The following is a description of a gene set: studied in species Mus musculus Mouse Gene Set: GOCC_LAMELLIPODIUM A thin sheetlike process extended by the leading edge of a migrating cell or extending cell process; contains a dense meshwork of actin filaments., and this is the list of marker genes: Scyl3, Bcar1, Wasf3, Abi3bp, Dmd, Flot2, Dbnl, Ptprz1, Dpp4, Scrib, Fgd1, Apc, Nckap1, Dgkz, Arpc3 (NCBI Gene Id 80396), Dysf (NCBI Gene Id 26903), Ccdc88a, Pkn2, Abi3, Arhgef6, Tiam2, Phpt1, Als2, Spata13, Rac2, Plce1, Mylk, Pxn, Fermt2, Pabpc1, Casp8, Pld2, Dynlt1f, Pkd2, Dbn1, Snx2, Piezo1 (NCBI Gene Id 234839), Dpysl3, Myo10, Palld, Swap70, Ptk2b, Actg2, Coro1a, Phactr4 (phosphatase and actin regulator 4), Pdpn, Ctnna1, Cdk5, Fam89b, Caprin1, Itgav, Rac1, Tescl, Syne2, Ilk, Myo1g, Sh3bp1, Acta1 (actin alpha 1, skeletal muscle), Stx2, Arap3, Mtss2, Gm28729, Ablim3, Wasf2, Stx3, Pstpip1, Twf2, Ptpn13, Pik3ca, Plekhh2 (pleckstrin homology domain containing, family H (with MyTH4 domain) member 2), Cib1, Rac3, Gsn, Igf2bp1, Parva, Dusp22, Tsc1, Mcf2l, Trpv4, Cyfip1, Itgb1bp1, Kitl, Stx4a, Klhl2, Dynlt1b, Actc1, Myh10, Abl2, Arpin, Ctnna3, Nradd, Plekhg5, Itgb3, Arpc5, Gdpd2, Dynlt1c, Cfl1, Tmod3, Arhgap31, Fat1, Ptk2, Slc39a6, Ctnnb1, Rab13, Coro1b, Nrbp1, P4hb, Inppl1, Trpv2, Coro1c, Rab3ip, Dynlt1a, Nedd9, Brk1, Dag1, Myo9b, Ajuba, Srcin1, Snx1 (NCBI Gene Id 56440), Clrn1, Wasl, Cdh2, Carmil3, Stmn2, Rock1, Wmp, Tubb3, Parvb, Epha2, Pak1, Aif1 (allograft inflammatory factor 1), Rdx, Carmil2, Stxbp2, Abitram, Ctnna2, Flot1, Ddx3x, Srgap2, App, Acta2, Arhgef7, Ppp1r9b, Apbb1ip, Cttn, Pip5k1a, Arpc2, Cspg4, Avil, Capzb, Wasf1, Angptl3, Actr3, Fap, Pear1, Cd44, Rnh1, Cdc42bpa, Podxl, Evl, Carmil1, Plek2, Pdxp, Rhoa, Ppp1r9a, Enah, Abi2, Spef1, Iqgap2, Fscn3, Kcna2, Cttnbp2nl, Itsn1, Rufy3, Myh9, Baiap2, Abi1, Limk1, Dnm2, Washc1, Fgd4, Antxr1, Unc5c, Hax1, Plxnd1, Pdlim4, Cdc42, Sorbs2, Rapgef3, Fscn1, Actr2, Mefv, Vil1, Cdc42bpb, Nf2, Tesk1, Sh3rf1, Capg, Snap25, Ablim1, Kptn, Vasp, Amotl1, Itgb1, Plcg1, Notch1, Fer, Amot, Dock8, Nme2, Tesc, Ctnnd1, Actb, Shtn1, Apc2, Pld1, Cdh1, Ptprm, Git1, Apbb1